Given this list of marker genes SERPINI2, AHDC1, BARD1, ZNF135, HMGB2, GCNT1, TOM1L1, SUPT20H, GSTT4, GRAP, ZNF749, DYRK4, ZNF239, MAST2, PMS2, TWF2, CXCL13, PPP1R16B, ZNF23, CACNA1E, ZBTB18, GABBR2, RUNX2, SMAD7, NOC2L, METTL3, CENPX, EOLA1, MORC2, TYR, SOX12, SERPINA1, TMEM30B, PPP2CA (NCBI Gene Id 5515), PTP4A1, PRKAB2, VAPB, ATG5, GPSM3, PHKA1, LYST, FOXC1, CCL19, VDAC1P3, RIN1, CHEK2 (NCBI Gene Id 11200), RALGPS1, JUN, GDF5, CLK2, SKIC2, KCNQ1, LTBR, FBXO46, CXCR6, GNRH1, PRKAB1, GFAP, GJA4, SIX1, PARG, LIMK2, HTR7P1, PAEP, MPDU1, CITED2 (NCBI Gene Id 154106), ETV1, GUSBP14, POLR1F, SLC12A1, FGF8, PPIH, PDXK, B3GAT3, CHRNB1 (NCBI Gene Id 1140), GLB1L2, ZNF217, SNUPN, CPSF1, DDX23, ADM, NEBL, DNMBP, SLC7A1, MDH2, CSTF1, SHC2, RRS1, ZNF274, PIAS3, RANBP6, UTY, DXO, RORC, SIPA1, SLC6A15, KLF10, DDX17, PSME3, ZP3, RAD17 (RAD17 checkpoint clamp loader component), NVL, ERCC6, OCA2, SYNGR3, RABGAP1L, ETFB, NGF, GRM5, ZNF205, SON, NCLN, CDK5, AP3M2, PMS2P3, THOC1, DNAH9, ZFP36, GALK2, HOXB13, GSTT2, DYRK2, MNAT1, SLC1A7, POLD2, KATNB1 (NCBI Gene Id 10300), NLRP1, SETDB1, LRRC17 (NCBI Gene Id 10234), SDC2, EPHA5, UGT8, NR2E1, EMG1, NOL4, SOCS5, NCAPH, PRKCB, PATZ1, NDUFB7, ERI3, NTSR1, NFYA, TCOF1, CCN1, PIM1, RDH11, RIPOR2, CCNT2, SPOP, SOCS1, IGHV1-2, ZNF710, RUNX1, BTN3A2, MED7 (mediator complex subunit 7), KLF6, MICAL2, SBF1, HIC1, KCNF1, PRDM2, CCS, MAPK11, SLC25A12, DYRK1A, GADD45A, MRPL49, KRR1, PPP1R3C, RBM4B, H4C12, PLEC, CAPN5, ZNF623, AURKA, LIN37, ABCC10, JRKL, ERG28, NR2F2, MOCS3, ZNF268, PIK3R4, ARHGEF4, TFCP2, CREBZF, SMAD3, HMBS, PDE4B, AMHR2, STARD13, ZBTB1, KLF7, PRKAR2A, MIOS, AP4S1, PTOV1-AS2, SOX1, MATK, GTF2E1, INPP5B, AVL9, CXCL6, POLB, OLIG2, CD5L, C3AR1, GZMK, B9D1, LRP8, AP1G2, PIP, ENSG00000293636, DUSP1, FZR1, RGS4, RUFY3 (NCBI Gene Id 441022), PLPBP, RXRA, ALDH1B1, RBM10, FCMR, TMEM186, MCC, ZNF101, NINL, PAFAH2, SCN8A, ZNF3, ODF2, HMGCL, DDIT3 (NCBI Gene Id 92982), GEMIN2, UMPS, ZNF195, KAT8 (lysine acetyltransferase 8), ACAA1, MYL5, KLHL9, POLG, PCSK7, CIT, NMNAT2, PTGER1, MPRIP, ABCA4, ZNF629, MICU1, TRIB2, SPECC1L, UTP25, MALL, RUNX1T1, here is a description of the gene set: species: Homo sapiens Genes down-regulated in primary fibroblast cell culture point after infection with HCMV (AD169 strain) at 4 h time point that were not down-regulated at the previous time point, 2 h. The effect of human cytomegalovirus (HCMV) infection on cellular mRNA accumulation was analyzed by gene chip technology. During a 48-h time course after infection of human diploid fibroblasts, 1,425 cellular mRNAs were found to be up-regulated or down-regulated by threefold or greater in at least two consecutive time points. Several classes of genes were prominently affected, including interferon response genes, cell cycle regulators, apoptosis regulators, inflammatory pathway genes, and immune regulators. The number of mRNAs that were up-regulated or down-regulated were roughly equal over the complete time course. However, for the first 8 h after infection, the number of up-regulated mRNAs was significantly less than the number of down-regulated mRNAs. By analyzing the mRNA expression profile of cells infected in the presence of cycloheximide, it was found that a minimum of 25 mRNAs were modulated by HCMV in the absence of protein synthesis. These included mRNAs encoded by a small number of interferon-responsive genes, as well as beta interferon itself. Cellular mRNA levels in cytomegalovirus-infected cells were compared to the levels in cells infected with UV-inactivated virus. The inactivated virus caused the up-regulation of a much greater number of mRNAs, many of which encoded proteins with antiviral roles, such as interferon-responsive genes and proinflammatory cytokines. These data argue that one or more newly synthesized viral gene products block the induction of antiviral pathways that are triggered by HCMV binding and entry. from publication Browne EP, Wing B, Coleman D, Shenk T (PMID 11711622) Human Gene Set: BROWNE_HCMV_INFECTION_4HR_DN